The following is a description of a gene set: Human Gene Set: GOBP_CELLULAR_RESPONSE_TO_STEROID_HORMONE_STIMULUS species: Homo sapiens Any process that results in a change in state or activity of a cell (in terms of movement, secretion, enzyme production, gene expression, etc.) as a result of a steroid hormone stimulus., and this is the list of marker genes: BCL2L11, RBFOX2, DEFA1B, ATP5F1A, NR0B1, HMGCS2, UBE2L3, ISL1 (ISL LIM homeobox 1), ESR1, SAFB2, FSHR (follicle stimulating hormone receptor), RPS6KB1, NEDD4 (NCBI Gene Id 4734), PIAS2, PMEPA1, PLPP1, ESRRG, DAXX, KANK2, MYOD1, SOX10, PAQR7, SMARCA4, RHOXF1, SCNN1B, USP26, MSTN, PKN1, SCNN1A, TRIM68, MED1, TGFB1, UFL1, ZFP36, PER1, RNF14, RWDD1 (RWD domain containing 1), HSPA1A, EP300, FOXP1, ETNPPL, AIFM1, PPARD, TAF7, SIRT1, NR2E1, TCF21, FOXA1, VDR, GSK3A, ASS1, SFRP1, ESRRB, SERPINF1, FKBP4, EDN1, NCOA1, PGR, HMGA2, CARM1, JAK2, NODAL (nodal growth differentiation factor), ATP1A3, DEFA1, ABCB1, ESR2, UFSP2, ATP1A1, POU4F2, DNAAF4, UBA5, NR2C1, PPARGC1B, RNF6, LMO3, PPARA, NPC1, NR3C1, DDX17, SRC, UBE3A, CRY1, NCOA4, LATS1, TRERF1, SKP2, HEYL, VPS54, ATP1A2, PAQR8, CNOT1, SSTR2, PCK2, ZNF366, SSTR4, TBX2, HNRNPU, ANXA1, LBH, RAN, KDM3A, NCOR1, PHB1, URI1, STRN3, STC1, KLF9, EGLN2, PARK7, HDAC1, EIF4E, SRARP, CBX3, DEFA3, HCN2, VPS18, SAFB, CDK12, ERRFI1, PAK1, TCF7L2, USP8, DDRGK1, BRCA1, TMF1, CFLAR, ZFP36L1, ESRRA, TRIP4, HDAC6, TADA3, ZDHHC7, TFPI, ZBTB7A, RXRA, SHQ1, NCOR2, ZNF764, ABHD2, TAF1, NKX3-1, PHB2, SCNN1G, HSPA8, GHRHR, SCNN1D, RHOA, CYP7B1, NPAS4, DAB2, ADTRP, CLOCK, ZFP36L2, FECH, KDM5D, CNOT9, HDAC2, CST11, SMYD3, PCK1, GSTP1, DDX54 (DEAD-box helicase 54), WBP2, SCGB2A2, PDE3A, FBXO32, VPS11, HSPA1B, GPER1, SCGB2A1, UBR5, FLT3, OR51E2, TFAP4, FOXH1, PADI2, BMI1 (NCBI Gene Id 648), AQP1, REST, NR3C2, NR2E3, AKR1C3, RXRG (retinoid X receptor gamma), CRH, UFM1, MGARP, KDM1A, FOXO3, IGF1, PAGR1, SSTR5, METTL21C, CRY2, NR1D1, PARP1, CASP9 (NCBI Gene Id 842), ZMIZ1, DDX5, SRD5A1, CALR, ACOD1, CNOT2, PPP5C, KMT2D, AR, CALCOCO1, PRMT2, MT-ND3, TP63, KDM4C, YWHAH, SGK1, RXRB, NR4A3, AXIN2, DDIT4, PGRMC2, FAM107A, BMAL1, CREBRF, CCDC62